Given this list of marker genes Fam234b, Rad9a, Tbx4, Adpgk, Fam168a, Rac3, Icmt, Cby1, 1700025G04Rik, Snurf, Rad23a, Amer3, Wnt9a, Thbs3, 1700102P08Rik, Parp6, Rgma, Chrm1 (NCBI Gene Id 12669), Bpifc, Slco2b1, C5ar2, Hnf1a, Anks4b, Mtus1, Lhfpl4, Hepacam, C2cd4c, Ccdc92b, Nuak2, Tirap, Setdb1, Anp32b, Nptx1, Sox10, Serf2, Rab5b, Rpp40, Ldb1, Map3k10, Gnao1, Tac4, Col5a3, Gp9, Kif26b, Dbndd1, Plppr2, Rbm14, Fam151b, Sec24c, AW554918, Daam2, Khnyn, Fbxo10, Tspan18, Vps16, Gatad2a, Hipk1, Atcay, Hoxb5, Hspb3, Elovl7, Fam131b, Alx4, Smarcad1, 2510039O18Rik, Xylt2, Wscd2, 1700006A11Rik, Ky, Gabpb2, Cd34, Tmem127, Cul3, Ncald, Atn1, Wt1, Rtl4, Atxn7l3, Nacc1, Kremen1, Ak4, Arrb1, Gm14326, Cfap44, Stk4, Tbx2, Chpf, Padi3, Enc1, Brpf3, Vps37d, Raly, Mag, Tbc1d22b, Heyl, Fcer2a, Rarb, Btrc, Tcf23, Col5a1, Khsrp, Usp4, Celf6, Nynrin, Cacnb1 (calcium channel, voltage-dependent, beta 1 subunit), Mbd6, Scrt2, H13, Trp53inp2 (NCBI Gene Id 68728), Dlk1, Vegfa, Lrch4, A530016L24Rik, Tgfbr2, Cnot9, Tmem86a, Kirrel1, Ttyh3, Lims2, Gm14391, Extl1, Drg2, Pef1, Best3, Slc25a20, Myocd, Gbp9, Bmf, Cxcr5 (C-X-C motif chemokine receptor 5, NCBI Gene Id 12145), Ppp1r12c, Rgs6, Fscn1, Tanc2, Tmem104, Rin3, Zfp777, B4galnt2, Zbtb46, Mycl, Pdpk1, Pitpnm2, Celf5, Phf2 (PHD finger protein 2), Spmip8 (sperm microtubule inner protein 8), Stc1, Igfbp5, Stk36, Abl1, Strn4, Fbxl16, Limk2, Efnb1, Aifm3, Oxsr1, Dennd4a, Sfxn3, Ammecr1, Per3 (period circadian clock 3), Dagla (diacylglycerol lipase, alpha), Sptbn4, Anxa9, Btf3l4, Mdga1, Dlx2, Lrrc8a (leucine rich repeat containing 8A VRAC subunit A), Mapkapk2, Arid3b, Ndel1, Glyr1, Kif1a, Dusp7, Ntsr1, Psmc4, Slc9a1, Fbxl19, Ptprt, Tbc1d16, Ankrd33b, Ahnak, Tpgs1, P2rx3, Fam53c, Snph, Bend3, Nxf1, Ephb3, Igf2, Spdef (SAM pointed domain containing ets transcription factor), Pimreg, Rnf44, Pnma8b (NCBI Gene Id 434128), here is a description of the gene set: from publication Chen Y, Wang X (PMID 31504780) Mouse Gene Set: MIR_6914_5P Genes predicted to be targets of miRBase v22 microRNA mmu_miR_6914_5p in miRDB v6.0 with MirTarget v4 prediction scores > 80 (high confidence targets). species: Mus musculus